The following is a description of a gene set: Spliceosome. Human Gene Set: MODULE_388 studied in species Homo sapiens, and this is the list of marker genes: SNRPB2, SF3A2, SNRPD1, SNRPD3, SNRPF, SNRPD2, SNRPA1, SF3A3, PRPF8, SNRPG, LSM1 (LSM1 homolog, mRNA degradation associated), SNRPE, SNU13, RRP9, SNRPC, SNRPA, EFTUD2